The following is a description of a gene set: part of: Processing of Capped Intron-Containing Pre-mRNA Reactome Pathway: mRNA Splicing electronically inferred by orthology from the curated human pathway This event has been computationally inferred from an event that has been demonstrated in another species.<p>The inference is based on the homology mapping from PANTHER. Briefly, reactions for which all involved PhysicalEntities (in input, output and catalyst) have a mapped orthologue/paralogue (for complexes at least 75% of components must have a mapping) are inferred to the other species. studied in species Mus musculus, and this is the list of marker genes: Lsm4, Xab2, Snrnp40, Tfip11, Polr2f, Polr2c, Srrt, Ubl5, Fam32a, Prpf19 (pre-mRNA processing factor 19), Rbmx, Hnrnpk, Ppil2, Ik, Syf2, Luc7l3, Magoh, Polr2e, Ddx23, Zfp830, Mtrex, Sf3b5, Snrpf, Snu13, Cdc40, Prpf18, Snrpa, Rbm17, Prkrip1, Hnrnph2, Prpf4, Polr2a, Wbp4, Casc3, Gtf2f2, Leng1 (leukocyte receptor cluster (LRC) member 1), Nsrp1, Steep1, Srsf10, Rbm22, Yju2, Sde2, Sf3a3, Cdc5l, Polr2b, Snrpg, Smndc1, Gpatch1, Snrnp35, Rbm5, U2af1l4, Pcbp1, Phf5a, Polr2k, Dhx16, Mfap1b, Prpf3, Nkap, Srsf3, Mfap1a, Sugp1, BC005624, Polr2i, Snrpc, Dhx35, Prcc, Snrnp27, Ddx41, Usp39, Zcrb1, Sart1, Rnf113a2, Hnrnpf, Snrpa1, Lsm2, Lsm6, Zmat5, Gtf2f1, Rnps1, Magohb, Polr2l, Cactin, Ptbp1, Pcbp2, Rnf113a1, Lsm8, U2surp, Srsf8, Eftud2, Snrpn, Cwc27, Srsf5, Upf3b, Snw1, Srrm2, Alyref, Ppig, Hnrnph1, Bud13, Snip1, Dhx8, Dhx15, Snrnp25, U2af2, Ppil1, Ctnnbl1, Hnrnpr